The following is a description of a gene set: studied in species Homo sapiens Reactome Pathway: Signaling by MAP2K mutants Activating mutations in MAP2K1 and MAP2K2, the genes encoding MEK1 and MEK2, have been identified at low frequency in a variety of cancers as well as in germline diseases such as Noonan syndrome, cardiofaciocutaneous syndromes and other RASopathies. part of: Oncogenic MAPK signaling, and this is the list of marker genes: MAP2K1, MAP2K2, MAPK1, MAPK3